The following is a description of a gene set: A MAPK cascade containing at least the ERK5 MAP kinase (MAPK7; also called BMK1). It starts with the activation of a MAP3K, and the consecutive activation of a MPK2K and of ERK5. The cascade can also contain an additional tier: the upstream MAP4K. The kinases in each tier phosphorylate and activate the kinases in the downstream tier. The ERK5 cascade is activated by stress, mitogens, and by G protein-coupled receptors, and results in cellular responses such as cell growth, cell differentiation and development. Human Gene Set: GOBP_ERK5_CASCADE species: Homo sapiens, and this is the list of marker genes: RAC1, MEF2A, ALKAL2 (NCBI Gene Id 285016), MAP2K5, RAP1GDS1, ALKAL1